Given this list of marker genes SLC51A, SLCO1B3, SLC10A1, BAAT, ABCC3, NCOA1, SLCO1B1, SLC27A5, FABP6, NCOA2, RXRA, SLC51B, NR1H4, ABCB11, STARD5, SLC10A2, ALB (NCBI Gene Id 29004), SLCO1A2, here is a description of the gene set: Of the 20-40 grams of bile salts released daily by the liver, all but approximately 0.5 grams are reabsorbed from the intestine, returned to the liver, and re-used. This recycling involves a series of transport processes: uptake by enterocytes mediated by ASBT (SLC10A2), traversal of the enterocyte cytosol mediated by ileal bile acid binding protein (I-BABP - FABP6), efflux from enterocytes mediated by MRP3 (ABCC3), travel through the portal blood as a complex with albumin, and uptake by hepatocytes mediated by Na+-taurocholate transporting protein (NTPC - SLC10A1) and, to a lesser extent by organic anion transporting proteins A, C, and 8 (OATPA - SLCO1A2, OATPC - SLCO1B1, and OATP-8 - SLCO1B3). Once returned to the hepatocyte cytosol, bile acids (generated in the intestine by the action of bacteria on secreted bile salts) are activated by conjugation with coenzyme A, then coupled to glycine or taurine, regenerating bile salts for re-export into the bile, mediated by the bile salt export pump, ABCB11. Unmodified bile salts returned to the hepatocyte cytosol can be re-exported by ABCB11 without further modification.<br> species: Homo sapiens Reactome Pathway: Recycling of bile acids and salts part of: Bile acid and bile salt metabolism